The following is a description of a gene set: The chemical reactions and pathways involving alpha-linolenic acid, an unsaturated omega-6 fatty acid that has the molecular formula C18H32O2. Mouse Gene Set: GOBP_ALPHA_LINOLENIC_ACID_METABOLIC_PROCESS species: Mus musculus, and this is the list of marker genes: Acot8, Elovl2, Acox1, Fads2, Acaa1b, Tmem135, Abcd2, Fads1, Hsd17b4, Acsl4, Acaa1a, Ehhadh, Abcd1, Elovl5, Scp2